The following is a description of a gene set: Human Gene Set: HP_ABNORMAL_GLOMERULAR_MESANGIAL_CELLULARITY Abnormal glomerular mesangial cellularity Abnormal number of its constituent cells of the mesangium of the glomerulus of the kidney. studied in species Homo sapiens, and this is the list of marker genes: LAMB2, KIRREL1, NOP10, COPA, SPRY2, APOE, SGPL1 (NCBI Gene Id 8879), CFHR5